Given this list of marker genes Dlgap4, Fabp5, Picalm, P2rx6, Vps35, Rpl7, Lck, Gapdh, Trappc4 (trafficking protein particle complex 4), Arhgef2, Gng3, Dgkb, Eps8, Tamalin, Camk1, Tiam1, Grm3, Map2, Syn3, Ctnna2, Pja2, Lrp8, Gsk3b, Rpl5, Anks1b (ankyrin repeat and sterile alpha motif domain containing 1B), Syt1, Crhr1, Camk2d, Lrfn2, Erbb4, Dnajb1, Arhgap44, Gpr50, Scn8a, Asic1, Atp1a1, Rps13, Lrrc4, Dst, Elfn1, Gabra2, Cabp1, Lin7a, Kcnab2, Mapk10, Abr, Pick1, Dlg1, Rps19, Pcbp1, Dbn1, Nsg2, Gabrg2, Epb41l1, Kpna2, Sigmar1, Rpl6, Igsf21, Itga8 (NCBI Gene Id 98963), Plppr4, Pip5k1c, Camk2b, Nck2, Arhgef9, Gabra6, Cacng7, Sharpin, Dlg4, Grik2, Inpp4a, Ina, Rps27rt, Wwc1, Prrt1, Nptn, Plcb4, Cpeb4, Atp7a, Psd, Gabrb3, Chrnb1, Klhl17, Camk2a, Pdpk1, Adra2a, Chrna4, Bsn, Septin11, Grip2, Lin7c, Pdlim5, Camk2g, Pten, Disc1, Gria2, Sos1, Syn2, Eif4g2 (eukaryotic translation initiation factor 4, gamma 2), Lrfn3, Mir132, Slc30a1, Crtac1, Hnrnpa3, Grin1, Cast, Chrm3, Kcnb1, Rpl14, Sema4b, Prickle2, Notch1, Plekha5, Rpl18a, Glra3, Rnf112, Rock2, Hnrnpd, Cacna1c, Cdh10, Clstn2, Grip1, Pacsin1, Fyn, Gap43 (NCBI Gene Id 14432), Rnf10, Homer3, Lrrc4c, Ddx3x, Lrrtm3, Nptx2, Prkn, Nsmf, Ptk2b, Rpl38, Kcnh1, Dynll2, Slitrk3, Lhfpl4, Cnih2, Lrp4, Grid2, Zdhhc2, Gria3 (glutamate receptor, ionotropic, AMPA3 (alpha 3)), Lrrtm2, Itpr1, Crtc1, Adgrb1, Rab8a, Grid1, Map4, Epb41l3, Ptprs, Rtn3, Mapk8ip2, Kcnd2, Cyth2, Nefh, Igsf9, Mapk1, Slitrk1, Ntrk2, Hnrnph2, Lrfn1, Rapgef4, Amot, Phb2, Eif3a (NCBI Gene Id 320318), Sh3kbp1, Fmr1, Prickle1, Erbin, Rgs9, Gria4, Bmpr2, Iqsec1 (NCBI Gene Id 79407), Hip1r, Elfn2, Kalrn, Chrne, Cpeb3, Celsr3, Ctnnd2, Cfl1, Add2, Arf1, Neurl1a, Cacng8, Chrna10, Chrna7 (NCBI Gene Id 11441), Grk3, Lrp1, Prrt2, Dgki, Rps25, Insyn1, Lrrc7, Rgs14, Mpp2, Chrnb4, Eef2k, Lrfn4, Olfm1, Magi2, Kcnk2, Mib1, Samd14, Psd3, Baalc, Epha7, Shank1, Mink1, Numb, Neo1, Dtnbp1, Vangl2, Abhd17c, Hnrnpa2b1, Htr5a, Mdm2, Cap2, Syt11, Dgkz, Ptprz1, Chrm1 (NCBI Gene Id 12669), Grm5, Rpl23, Map3k7, Gabra5, Grik1, Shank2, Ryk, Rplp0, Dicer1, Scrib, Sh2d5, Rims1, Ngfr, Drd5, Rapsn, Chrna1, Pcbp2, Tanc2, Arc, Adra2c, Gphn, Il1rapl1, Bnip3, Efnb2, Slc16a7, Pde4b, Tnik, Usp8, Chrnd, Chrnb2, Als2, Usp50, Add1, Ywhaz, Ank2, Nefm, Csmd2, Ppfia2, Sipa1l1, Snx1, Akap5, Cd200, Dnm3, Cacng5 (NCBI Gene Id 140723), Dcc, Ablim1, Slc16a3, Cit, Shisa8, Grin2d, Shisa6, Dvl1, Macf1, Gabra1, Prkcz, Dtnb, Rpl10a, Dlg5, Chrna3, Zdhhc15, Slc8a3, Lzts3, Camk2n1, Tacc3, Sh3gl1, Dnajc6, Mapt, Rps14, Rps6kc1, Afdn, Gabrb1, Pclo, Baiap2, Negr1, Sipa1l3, Abhd17a, Rusc1, Syndig1, Cadm1, Rtn2, Shisa9, Hnrnpm, Cacng2, Cdkl5, Gpsm2, Map2k1, Dagla, Add3, Tanc1, Brsk1, Rbmx, Abhd17b, Glrb, Gabrb2, Aurka, Arhgap33, Ptpro, Gopc, Synpo, Oprd1, Shank3, Shisa7, Lrfn5, Dnm2 (dynamin 2), Neto2, Prr12, Gria1, Fam81a, P2ry1, Grik4, Lrrtm1, Cacng4, Yes1, Syngap1, Ppp1r9b, Sema4c (NCBI Gene Id 98332), Src, Robo2, Map1b, Slc8a1, Mir134, Map1a, Gsg1l, Akap9, Ank3, Gabra3, Rtn1 (NCBI Gene Id 97843), Insyn2a, Atp2b2, Tsc1, Sorcs3, Chmp4b, Rtn4, Rpl12, Vdac1, Casp3, Neto1, Nos1, Adgrb3, Dlgap3, Abi3 (ABI family member 3), Kcnt1, Rgs7bp, Gabra4, Pkp4, Mpdz, Rps18, Abi1, Palm, Capzb, Sorcs2, Dmtn, Cnksr2, Cdh2, Dlgap1, Grik3, Rps27, Arhgap32, Drosha, Abl1, Abi3bp, Gapdhrt, Prnp, Akap1, Pak3, Pak2, Hspb1, Gper1 (NCBI Gene Id 76854), Lin7b, Lzts1, Grin2a, Efnb3, Phb1, Nr3c1, Spock1, Fbxo45, Chrna9, Slitrk5, Srgap2, Mkln1, Cdk5r1, Adcy8, Dapk1, Hspa8, Dgcr8, Iqsec2, Dnm1l, Grm1, Flrt3, Asic2, Grin2b, Slc6a9, Mtmr2, Nectin3, Adam22, Slc8a2, Dlg3, Egln1, Snap91, Lyn, Tsc2, Epha4, Sema4f, Ppp1r9a, Glra1, Nlgn1, Actn2, Dbnl, Grin3a, Rheb, Gpr158, Syn1, Ptprt, Cacng3, Cript, Ptprf, Cpeb1, Hnrnph1, Prkcg, Pak6, Kcnd3, Anp32e, Sptbn1, Homer2, Adam10, Adcy1, Tmem240, Dpysl2 (NCBI Gene Id 12934), Grin3b, Pak1, Dlgap2, Ube3b, Prr7, Ctnnb1, Zdhhc5, Grk2, Tmem108, Stx1a, Grid2ip, Homer1 (homer scaffolding protein 1), Nlgn4l, Drd3, Olfm2, Ctnnd1, Mir99a, Eif3e, Git1, Fgf22, Bcr, Rpl4, Grin2c, Nrg1, Clstn1, Dclk1, Glra4, Rps3, Rpl30, Kpna1, Dmd, Myo6, Ncs1, Arfgap1, Nrcam, Cdk5, Iqsec3, Vhl, Nlgn2, Chmp2b, Nr3c2, Frmpd4 (NCBI Gene Id 414749), Clstn3, Chrm4, Srcin1, Syp, Exoc4, Nlgn3, Drp2, Grik5, Adgra1, Slc12a5, Lrrtm4, Pura, Glra2, Snap47, Igsf11, Sh3gl3, Lrrc4b, Rpl8, Stat3, Dlg2, Erc1 (NCBI Gene Id 78063), Gapdhrt2, Igsf9b, here is a description of the gene set: species: Mus musculus Mouse Gene Set: GOCC_POSTSYNAPTIC_SPECIALIZATION A network of proteins within and adjacent to the postsynaptic membrane. Its major components include neurotransmitter receptors and the proteins that spatially and functionally organize them such as anchoring and scaffolding molecules, signaling enzymes and cytoskeletal components.